The following is a description of a gene set: studied in species Mus musculus A molecular function regulator that inhibits or decreases the activity of its target via non-covalent binding that does not result in covalent modification to the target. Mouse Gene Set: GOMF_MOLECULAR_FUNCTION_INHIBITOR_ACTIVITY, and this is the list of marker genes: Bst2, Itih2, Wfdc3, Kdm5a, Nfkbil1, Cftr, Cstdc4, Gnaz (NCBI Gene Id 14687), Csn2, Itpr1, A2m, Kng1, Ppp1r14b, Cast, Nrros, Stx7, Hamp2, Gckr, Serpini1, Bex3, Serpina6 (NCBI Gene Id 12401), Serpina1f, Tsacc, C4b, Mansc4, Ppp1r14c, Col6a3, Myoz1, Socs5, Mtrnr2l7, Cst9, Hyal2, Ptprc, Fetub, Tescl, Reck, Ly6g6d, Tmx1, Rtkn, Nherf4, Cst13, Prex1, Ppp1r2, Styxl1, Ly6c2, Serpinb1a, Acd, Sost, Kcne4, Serpinb9f, Hes6, Dgki, Ten1, Ctla2b, Ppp1r1a, Snca, Serpina16, Pkia, Id2, Abce1, Gchfr, Ly6h, Serpine1, Ywhab, Wfdc15a, Spink8, Wfdc6a, Styx-ps, Hspb1, Apoc1, Gapdhrt2, Tmem225, Prnp, Pln, Cmya5, Adgrv1, Csta1, Mbip, Wfdc6b, Serpinb3c, Pi15, Pot1a, Mug2, Cstb, Trib1, Serpinb9h (NCBI Gene Id 544923), Zfp451, Ngp, Ezhip, Dffa, Ywhae, Wap, Dtx3l, Akt1, Smr3a, Macroh2a1, Trib3, Agrn, Trappc2b, Uri1, Spink7, Atp5if1, Tnni3, Sh3bp5l, Serpinb8, Snip1, Cep43, Adh7, Cib1 (NCBI Gene Id 23991), Apoa2, Apba3, Phactr3, Serpinb9d, Fkbp1b, Dkk3, Spint1, Ppp1r37, Dnajc3, Wnk4, Smo, Serpina3j, Serpina1a, Serpini2, Clec12b, Ppp1r14a, Stx1a, Nfkbia, Pacsin3, Brsk1, Calm1, Dusp22, Spink13, Reg1, Gm28729, Spint4 (serine protease inhibitor, Kunitz type 4), Hamp, Serpina3a, Serpinb9e, Gm7298, Ppp1r1c, Lypd6, U2af2, Anxa3, Inca1, Serpinb13, Col7a1, Wfdc1, Wfdc15b, Hexim1, Bin1, Otub1, Spred1, Tesc, Styx, Naip1, Lynx1, Slpi, C3, Cdkn1c, Arpp19, Tfpi, Csta2, Cstdc5, Parp9, Birc5, Parva, Timp2, Ly6m, Nlrp2, Rps20, Fry, Ly6g6g, Dusp19, Elfn2, Spink12, Camk2d, Rpl37rt, Id3, Wfdc21, Ly6e, Zfas1, Nkx3-1, Cstdc6 (NCBI Gene Id 100038854), Spock3, Faf2, Ppp1r16a, Ambp, Angpt2, Stfa2l1, Per2, Fnip2, Serpinf1, Ltbp1, Pinlyp, Angptl4, Atp2b1, R3hdml, Chmp3, Spink2, Aplp2 (NCBI Gene Id 11804), Usp10, Socs1, Serpinb3d, Ly6g2 (NCBI Gene Id 223631), Cst11, Ppp1r27, Tsc1, Sh3rf2, Mcrs1, Fst (NCBI Gene Id 99160), Cit, Serpina3n, Crb2, Fkbp1a, Spink5, Crim1, Serpina3k, Rnh1, Npm1, Cstdc1, Cd55, Cav3, Serpinb3a, Cst8, Pi16, Tmc7, Tfpi2, Lrpap1, Cst3, Slc15a1, Cstl1, Sirpa, Tank, Atad3a, Lrrc32, Bsn, Slurp2, Rpl23, Micu1, Glmn, Ugt1a9, Mrln, Cd55b, Ppp1r36, Reg2, Lamp1, Mcub, Nr0b2, Cdkn2a, Sin3a, Cdkn2b, Prkar1a, Phpt1, Wfdc12, Tprn, Rack1, Serping1, Csta3, Serpina1e (serine (or cysteine) peptidase inhibitor, clade A, member 1E), Pde6d, Umodl1, Cstdc3 (cystatin domain containing 3), Socs3, Hrg, Trib2, Keap1, Slit2, Mgat5, Pcsk9, Ppp1r10, Wnk3, Pot1b, Anp32e, Gapdhrt, Wfdc18, Pkig, Sbf1, Lyar, Serpinb6b, Bod1, Ngf, Ppp1r14bl, Stfa2, Stfa3, Smr2, Ppp1r35, Agt, Serpinb9g, Timp3, C1qbp, Serpinb6e, Dgkz (NCBI Gene Id 352984), Lamp2, Smr2l, Inka1, Itih5, Vamp8, Pebp1, Spry4, Ppp1r17, Bex1, Tcf23, Pcsk1n, Pkd1, Mug1, Dbn1, Ibtk, Serpinb10, Pif1, Eppin, Spop, Ppp1r11, Ppp1r12c, Ugt1a10, Gpc3, Frat1, Cst12, Renbp, Smad7, Gbp2b, Kng2, Cdkn1a, Spink10, A2ml1, Itih3, Wfdc2 (WAP four-disulfide core domain 2), Serpind1, Serpinf2, Ppp1r14d, Prkar1b, Scgb1a1, Camk2n2, Cdkn2c (NCBI Gene Id 97133), Hspa5, Serpina1c, Serpinh1, Spink6 (NCBI Gene Id 433180), Gnai1, Serpina1b, Serpinb9, Rcan1, Nolc1, Pttg1, Cdkn1b, Prkag2, Rpl11, Rgs2, Calu (calumenin), Lypd1, Pkd2, Papln (NCBI Gene Id 268570), Cpeb2, Akt1s1, Stfa1, Simc1, Phactr1, Prkch, Serpinb6c, Oas1d, Ugt1a8, Timp1, Scn3b, Nedd4, Itprip, Wfikkn2, Elfn1, Wfdc13, Itih4, Scg5, Col28a1, Uchl5, Pzp, Inka2, Gapdh-ps15, Bcl2, Ankrd42, Hsp90ab1, Xiap (X-linked inhibitor of apoptosis), Ppp2r5a (NCBI Gene Id 226849), Wfdc5, Ly6i (NCBI Gene Id 57248), Elk1, Rhoh, Lrp6, Serpina7, Adrm1b, Wnk2, Fbxo5, Hnrnpc, Stom, Serpinb6d, Wfdc11, App, Spock1 (NCBI Gene Id 20745), Pkib, Ppp1r16b, Serpinb3b (NCBI Gene Id 383548), Camk2n1, Serpinb1b, Itih1, Cst7 (NCBI Gene Id 13011), Calm3 (NCBI Gene Id 97428), Dnajb1, Serpinb6a, Lmtk2, Psmf1, Pmp22, Calm2 (NCBI Gene Id 75700), Ankle2, Gmppa, Spry2, Wfdc16, Serpina3c, Wfikkn1, Serpinb9b, Ccl5 (NCBI Gene Id 20304), Oaz1, Sh3bp5, Hexim2, Serpina3m, Txnip, Uaca, Apoc2l, Serpine3, Stoml1, Phactr4, Atp2b4, Serpinc1, Serpinb12 (serine (or cysteine) peptidase inhibitor, clade B (ovalbumin), member 12), Igfbp2, Commd1, Ensa, Dut, Gbp2, Rps7, Wnk1 (NCBI Gene Id 406236), Lef1 (NCBI Gene Id 99641), Serpina3i, Usp14, Gprc5b, Wfdc9, Serpina3f, Ppp1r12a, Tfdp1, Ptp4a2, Sumf2, Ppp1r1b, Serpina5, Nedd4l, Cst5, Qars1, Id4, Prex2, Ppp1r12b, Ccar2, Tmeff1, Stx8, Gskip, Pabir2, Wars1, Ly6a, Kat2b, Ano9, Il1rn, Dkkl1, Dkk2, Serpina11 (NCBI Gene Id 380780), Cdkn2d, Lxn, Fnip1, Limk1, Pcyt1a, Id1, Dus2, Spint2, Prkar2b, Kcnab1, Wdtc1, Bex4, Wfdc8, Apoc2, Tiprl, Pten, Ppp1r26, Adrm1 (adhesion regulating molecule 1 26S proteasome ubiquitin receptor), Pak1ip1, Spink1 (serine peptidase inhibitor, Kazal type 1), Cd109, Clstn3, Sorl1, Grm7, Wfdc10, Serpinb7, Taf1, Ucn, Ski, Anxa1, Sri, Oaz2, Serpina1d, Park7, Ly6c1, Dkk4, Ppef2, Wfdc17, Ahsg, Birc6, Apoa1, Smtnl1, Timp4, Cip2a, Prkrip1, Cry2, Bex2, Rptor (regulatory associated protein of MTOR, complex 1), Casp3, Deptor, Spink4, Scn1b, Prkar2a, Vti1b, Oaz3, Serpina10, Rps15, Gbp5, Pbp2, Furin, Ppp1r8, Serpina9, Daxx, Ly6f, Tmbim6, Anxa2, Ly6g, Serpina3b (NCBI Gene Id 271047), Serpinb2, Ppp4r4, Gbp4, Spred2, Serpina3g, Ppp1r9b (NCBI Gene Id 217124), Chp1, Hsp90b1, Serpinb1c, Notch1, Gapdh, Nlrc3, Cav1, Slc30a1, Spint3, Birc7, Inhca, Pinx1, Pura (NCBI Gene Id 70733), Lilrb4a, Angptl3, Apoc3, Flcn, Cabin1, Ltf, Ptn, Ppt1, Kcnk2, Peg12 (NCBI Gene Id 27412), Smad6 (NCBI Gene Id 17130), Serpinb5, Serpinb11, Serpina12, Dynll1, Dkk1, Thrsp, Serpinb9c, Hc, Htra2 (HtrA serine peptidase 2), Lrrk2, Smcr8, Lilrb4b, Pabir1, Serpine2, Rpl5, Spink11, Rpl37, Rarres1, Nck1, Ugt1a7c, Ddit3, Arrb1, Ugt1a1, Taf3, 2810408A11Rik, Igsf1, Thbs1